The following is a description of a gene set: Genes predicted to be targets of miRBase v22 microRNA hsa-miR-4445-3p in miRDB v6.0 with MirTarget v4 prediction scores > 80 (high confidence targets). from publication Chen Y, Wang X (PMID 31504780) Human Gene Set: MIR4445_3P species: Homo sapiens, and this is the list of marker genes: EIF4E3, GPATCH2L, EIF4G2, PPP3CA, MIER3, CENPBD1P, ATRNL1, NSD2, EPHA4, RNF43, ZNF292